The following is a description of a gene set: species: Mus musculus Mouse Gene Set: GOMF_LRR_DOMAIN_BINDING Binding to a LRR domain (leucine rich repeats) of a protein., and this is the list of marker genes: Cdc5lrt9, Stk11, Dapk3, Scn2a, Polr2j, Aatf, Lrrfip2, Cdc5lrt5, Cdc5lrt8, Cdc5lrt6, Cdc5lrt7, Kras, Mrtfa, Robo1, Nrl, Pmf1, Crx, Pawr, Cdc5lrt10, Atf4, Cdc5lrt4, Cdc5l, Ddit3, Atf2, Jdp2, Ncam1, Zxdc, Cdc5lrt1